Given this list of marker genes AGER, PPP2R5D, ALPK1, CASP8, VRK3, IKBKE, MAPK10, IRF3, NKIRAS2, NFKB1, FADD, MAPK14, TIFA, RIPK2, ATF1, USP18, CREB1, LY96, MAPK3, PPP2R1A, ATF2, NLRC5, RPS6KA5, NFKB2, IKBKB, MAP2K3, PTPN11, NOD1, FOS, PPP2R1B, MAPK9, TLR4, RPS6KA1, RPS6KA2, TANK, S100A12, JUN, PPP2CB, PPP2CA, UBE2N, S100B, MAP2K4, RPS27A, MAP2K7, TAB3, MAP2K6, TICAM2, TAB2, NKIRAS1, UBE2D1, UBA52, MAPK7, CHUK, MAP3K8, BIRC2, USP14, TBK1, UBE2V1, FBXW11, RELA, TRAF3, SKP1, CD14, MEF2A, TP53, SAA1, TICAM1, APP, TNIP2, MAPK11, NOD2, MAPKAPK3, TRAF6, NLRX1, NFKBIB, RIPK3, IRF7, TAB1, ELK1, NFKBIA, DUSP6, TRAF2, CUL1, UBE2D2, MEF2C, RIPK1, SARM1, IRAK1, UBE2D3 (ubiquitin conjugating enzyme E2 D3), OPTN, BIRC3, MAPKAPK2, HMGB1, MAP3K7, MAP2K1, UBB, IKBIP, IKBKG, RPS6KA3, UBC, N4BP1, BTRC, DUSP4, DUSP3, IRAK2, N, LRRC14, MAPK8 (mitogen-activated protein kinase 8), DUSP7, MAPK1 (mitogen-activated protein kinase 1), here is a description of the gene set: part of: Toll Like Receptor 4 (TLR4) Cascade The MyD88-independent signaling pathway is shared by TLR3 and TLR4 cascades. TIR-domain-containing adapter-inducing interferon-beta (TRIF or TICAM1) is a key adapter molecule in transducing signals from TLR3 and TLR4 in a MyD88-independent manner (Yamamoto M et al. 2003a). TRIF is recruited to the ligand-stimulated TLR3 or 4 complex via its TIR domain. TLR3 directly binds TRIF (Oshiumi H et al 2003). In contrast, the TLR4-mediated signaling pathway requires two adapter molecules, TRAM (TRIF-related adapter molecule or TICAM2) and TRIF. TRAM(TICAM2) is thought to bridge the activated TLR4 complex and TRIF (Yamamoto M et al. 2003b, Tanimura N et al. 2008, Kagan LC et al. 2008).<p>TRIF recruitment to the TLR complex stimulates distinct pathways leading to the production of type I interferons (IFNs) and pro-inflammatory cytokines and to the induction of programmed cell death. Reactome Pathway: MyD88-independent TLR4 cascade species: Homo sapiens